Given this list of marker genes Ptpmt1, Ucp2, Rest, Mup11, Inhbb, Adra2a, Lep, Nucb2, Uts2, Ghrl, Pparg, Mup4, Ndufaf2, Mup5, Sirt4, Npff, Abcc8, Ptpn11, Gnai1, Srebf1, Rptor, Ptger4 (NCBI Gene Id 19219), Madd, Ptger3, Eny2, F2rl1, Ffar3, Ffar2, Pfkl, Kcnq1, Ffar4, Hadh, Stxbp5l, Crhbp, Tbc1d1, Mup1, Vsnl1, Pde1c, Acvr1c, Map4k4, Drd2, Ghsr, Pde3b, Ccn3, Mtnr1b, Sirt1, Pde8b, Nos1, Prkn, Psmd9, Crh, Irs1, Mtnr1a, Anxa5, Ptprv, Sytl4, Pim3, Klf7, Kcnb1, Fkbp1b, Gnaz, Jagn1, Hmgcr, Foxo1, Sfrp1, Cartpt, Fbn1, Mup3, Kcnj6, Kalrn, Mup2, Chga, Kcnj11, Crhr2, Fam3d, Midn (NCBI Gene Id 70193), Gnao1 (guanine nucleotide binding protein, alpha O), Ppp3ca, Cd74, Pde4c (phosphodiesterase 4C, cAMP specific), here is a description of the gene set: Any process that stops, prevents, or reduces the frequency, rate, or extent of peptide secretion. studied in species Mus musculus Mouse Gene Set: GOBP_NEGATIVE_REGULATION_OF_PEPTIDE_SECRETION